The following is a description of a gene set: from publication Cui Y, Zheng Y, Liu X, Yan L, Fan X, Yong J, Hu Y, Dong J, Li Q, Wu X, Gao S, Li J, Wen L, Qiao J, Tang F (PMID 30759401) Human Gene Set: CUI_DEVELOPING_HEART_TRABECULAR_VENTRICULAR_CARDIOMYOCYTE species: Homo sapiens, and this is the list of marker genes: WDR12, DHCR7, CYP51A1, CCN1, HBEGF (heparin binding EGF like growth factor), CD24, ABHD12, RTCB, GET1, H2AC25, TNNT1, ISOC1, MRPL13, RGS3, NET1, SLC2A1, TRH, KRT19, SPINT2, DEPP1, BUB3, HEY1, NOP16, ARRDC3, DNAJB1, RASD1, SGPL1, GEM, TRAPPC3, IER2, MSMO1, HSPA5, KPNA2, NPPB, SIGMAR1, NEURL2, EXOSC8, PRKDC, GALE, MGST1, HES1, VCAM1, HSPB8, GMNN, VCAN, DENR, TSPAN13, CTSV, EPSTI1, LINC01405, ARL4D, SKIL, ANXA3, XRCC4, HNRNPL, VPS33A, CLDN6, COX6A1, COL2A1, DDIT3, CDH3, LRRC49, TMEM88, HERPUD1, B3GNT2, MLLT11, PPP1R15A, MPHOSPH6, ABHD16A, RXRG, HMGCR, SLIT2, TNFRSF12A, SCD, CRABP2, HMGA2, TOB1, MYH6, REEP6, SMTNL2, CCDC181, HAMP, ANGPT1, HTR3B, SQLE, YWHAQ, SDF2L1, SLC3A2, KRT8, CD320, RC3H1, PIP4P2, RCAN1, PGAM4, LIX1, CCN2, DGKI, RASL11B, TIMM17A, KLHL31, KCNH7, LRPAP1, FAM118B, EBP, SRSF6, COMMD10, PDGFD, S1PR1, INSIG1, PHACTR3